Given this list of marker genes Bdkrb2, Hrh2, Ntsr1, Pla2r1, Pla2g3, Hrh3, Mif (macrophage migration inhibitory factor (glycosylation-inhibiting factor)), Pla2g6, Ace, Kiss1r, Pla2g12a, Sstr4, Drd4, Drd2, Avpr1b, Atp5pf, Pnpla8, Lhcgr, Anxa1 (annexin A1), Pla2g2c, Pla2g2f, Nmur2, Proca1, Pla2g1b, Nmb, Syk, Pla2g4f, Pla2g10, Oc90, Drd3, Pla2g2d, Pla2g12b, Pla2g5, Pla2g2a, Pla2g2e, Pla2g4a (phospholipase A2, group IVA (cytosolic, calcium-dependent)), here is a description of the gene set: studied in species Mus musculus Mouse Gene Set: GOBP_ARACHIDONATE_SECRETION The controlled release of arachidonic acid from a cell or a tissue.